The following is a description of a gene set: Catalysis of the transfer of an alkyl or aryl (but not methyl) group from one compound (donor) to another (acceptor). Mouse Gene Set: GOMF_TRANSFERASE_ACTIVITY_TRANSFERRING_ALKYL_OR_ARYL_OTHER_THAN_METHYL_GROUPS studied in species Mus musculus, and this is the list of marker genes: Mat1a, Mat2b, Mat2a, Fntb, Dph1, Pdss1, Gstm5, Mmab, Dtwd1, Rabggtb, Gsta4, Pdss2, Tsr3, Fdps, Gstt3, Gstt1, Gsta13, Gstm3, Gsta3, Sms, Dtwd2, Lancl1, Gstp-ps, Dhdds, Gstm2, Trmt12, Cox10, Gstt2, Ggps1, Gstp3, Ubiad1, Agps, Mgst3, Gstm7, Ltc4s, Gstp1, Rabggta, Dhps, Gstt4, Pggt1b, Gstp2, Sec14l2, Hpgds, Hmbs, Srm, Gsta5, Gsta2, Mgst2, Gstm4, Gstk1, Ptar1, Dph2, Fnta, Nus1, Trit1, Alox5ap, Nans, Ptges, Gstz1, Gstm1, Gsto2, Coq2, Gsto1 (NCBI Gene Id 226190), Gstm6, Fdft1, Mgst1, Gsta1